Given this list of marker genes ERCC4, PEX1, COA8, BBS9, BBS2, RP2, RBP3, IFT140, MT-ND5, MFSD8, TRIM37, SDHAF1, POLR3A, SCAPER, RAB28, PEX5, MT-ND2, SAG, OFD1, IMPG2, ISCA1, ALMS1, CNGA3, LCA5, CLCC1, MKS1, ERCC3, ROM1, SDHB, PITPNM3, MT-ND6, FAM161A, DHX38, CERKL, GUCY2D, IDH3B, MT-TL1, MSTO1, IMPG1, MORC2, MED12, NCAPG2, CRX, NOTCH2NLC, DRAM2, MAK, NGLY1, MPV17, DHDDS, PRPF3, POC1B, ARL2BP, PNPLA6, JAG1, RP1L1 (NCBI Gene Id 94137), CACNA1F, CFAP418, SLC24A1, NR2E3, HGSNAT, RRM2B, TUB (TUB bipartite transcription factor), RPGRIP1, POMT2, FKRP, PROM1, RHO, REEP6, PISD, NMNAT1, UNC119, MT-TQ, LAMB2, MFRP, PUS1, BBS5, RPGR, LRAT, NRL, PRCD, MECR, COX7B, MT-ND4, SEMA4A, CCDC28B, CA4, OPN1MW, MT-TW, AHR, MT-ND1 (NCBI Gene Id 4535), LARGE1, RNASEH1, MT-TK, MT-ATP6, GUCA1B, CDHR1, MERTK, GMPPB, HK1, MKKS, CLRN1, RGR, POMT1, GSS, TTPA, RDH12, PRPF31, CYP4V2, PANK2, NDUFAF1, RP1, RPE65 (NCBI Gene Id 6121), ADAM9, HCCS, TOPORS, MT-CO1, CNGB1, USH2A, PDE6A, PDE6B, RNU4ATAC, KLHL7, PRPH2, ARHGEF18, HADH, MT-CO3 (NCBI Gene Id 4514), CTNS, HADHB, SNRNP200, PDE6G, TTC8, TULP1, RAX2, ARL6, MT-TV, RIMS1, CAV1, SDHD, ARL13B, MMACHC, IFT43, POMGNT1, MT-TN, ZFYVE26, SPATA7, CNNM4, VPS13B (vacuolar protein sorting 13 homolog B), CRB1, ZNF513, ARL3, SURF1, MT-ND3, PCARE, CHM, CC2D2A, AHI1, KIAA1549, PRPF8, GUCA1A, HADHA, BBS1, AIRE, IFT172, RDH11, ABCA4, WFS1, ATF6, NEK2, COX8A (NCBI Gene Id 1351), IFT88, PRDX1, HKDC1, ARSG, ZNF408, MT-TS2, PEX2, KIZ, MT-CO2, MT-TF, PRPF6, TRNT1, IDH3A, AMACR, GRM6, AIPL1, TLCD3B (TLC domain containing 3B), RP9, RLBP1, MT-TH, SLC7A14, FLVCR1, NDUFB11, ACOX1, TIMP3, TTLL5, ATXN7, AGBL5, ERCC8, CFAP410, LZTFL1, FSCN2, IMPDH1, MT-ATP8, BEST1, PRPF4, OPN1LW, CNGA1, CACNA2D4, EYS, RDH5, ERCC6, SDHA, here is a description of the gene set: Pigmentary retinopathy Human Gene Set: HP_PIGMENTARY_RETINOPATHY An abnormality of the retina characterized by pigment deposition. It is typically associated with migration and proliferation of macrophages or retinal pigment epithelial cells into the retina; melanin from these cells causes the pigmentary changes. Pigmentary retinopathy is a common final pathway of many retinal conditions and is often associated with visual loss. species: Homo sapiens